Given this list of marker genes Abi3, Ybx1, Cgas, Cdk6, Nek4, Abl1 (NCBI Gene Id 98922), Plk2, Bcl6, Kras, B2m, Zkscan3, Terf2, Bcl2l12, Bmal1 (basic helix-loop-helix ARNT like 1), Rbl1, Zfp277, Zmpste24, Sirt1, Fzr1, Sirt6, Nampt, Hmga2, Ang, Twist1, Arg2, Mtor, H2-M3, Map3k3 (NCBI Gene Id 26406), Eef1e1 (NCBI Gene Id 66143), Bmpr1a, Icmt, Suv39h1, Nuak1, Akt3, Tert, Pten, Ilk, Mif, Vash1, Trp63, Trp53, Rsl1d1, Fbxo5, Gch1, Pawr, Morc3, Pnpt1, Prkdc, Wnt1, Tbx2, Ypel3, here is a description of the gene set: Any process that modulates the frequency, rate or extent of cellular senescence. studied in species Mus musculus Mouse Gene Set: GOBP_REGULATION_OF_CELLULAR_SENESCENCE